Given this list of marker genes RTN4, SQLE, PLPPR5, PIKFYVE, CLIC5, ICA1L, SINHCAF, SDC4, ILDR2, EXOC6, KDM4A, VKORC1L1, EPHB4, ERGIC1, PLK2, BNC2, CASTOR2, BOK, DOK1, PCSK6, TMEM86A, ARRB2, THTPA, PPP3R2, DLL3, FAM218A, KPNA6, PPM1A, NAP1L1, TMEM72, PTPN4, CTDSPL2, KLHL14, UBE2K, PHACTR1, KDM2A, SEMA4C, VLDLR, XKR4, IPO5, SLC1A7, DDX6, CALHM2, CLTC, CHD2, ZDHHC22, TBC1D22B, MPP2, KCTD15, CELF2, IL19, COL27A1, ZC3H13, CLSTN2, C3orf70, CPEB2, LSAMP, PAFAH1B2, PRRC2B, SLC25A37, EI24, CCNK, PROX1, POU2F1, CCDC120, TNRC6B, ZBTB14, PCSK1, SH3BP5, NFIA, TMEM164, CLOCK, RAPH1, HP1BP3, HDAC1, VGLL4, HMGXB3, NUP35, FOXG1, TTC17, EPB41L1, NALF2, PRPF19, LSM2, NTRK3, ZBTB10, SPTLC2, RCAN2, C2orf88, SAMD7, AGAP1, NFAT5, DGKK, MATN2, BEAN1, ADRA1A, PPP2R5B, TRIM65, RELT, here is a description of the gene set: from publication Chen Y, Wang X (PMID 31504780) Genes predicted to be targets of miRBase v22 microRNA hsa-miR-6756-3p in miRDB v6.0 with MirTarget v4 prediction scores > 80 (high confidence targets). species: Homo sapiens Human Gene Set: MIR6756_3P